The following is a description of a gene set: Human Gene Set: HP_ABNORMAL_NIPPLE_MORPHOLOGY An abnormality of the nipple. species: Homo sapiens Abnormal nipple morphology, and this is the list of marker genes: FGF8 (fibroblast growth factor 8), CHD7, ERCC3, MAP2K1, TRAF7, ALG11, CCDC22, GNPTAB, PIGO, TFAP2A, KDM6B, VPS35L, RRAS2, TNRC6B, UBE2A, ARHGEF2, FIG4, SRD5A3, COX7B, KIAA0586, GPC3 (NCBI Gene Id 6394), KDM5B, PEX3, KRAS, FGFR2, SOS1, TOGARAM1, DHCR7, HDAC4, ALG2 (NCBI Gene Id 85365), CDK13, IDH1, MADD, HNRNPK, AHDC1, SMS, PIK3CD, SOX6, WASHC5, ANTXR1, IBA57, CPLX1 (NCBI Gene Id 10815), DPAGT1, DPM1, BICRA, RAB3GAP2, ZMYND11, WDR37, GNB2, SPIN4, RTL1, CARS1, TTC5 (tetratricopeptide repeat domain 5), GNRH1, CHRNG, RIT1, ABCD4, LAMA5, SLC25A46, HS2ST1, FGF17, ARCN1 (archain 1), RAF1, PROK2, COLEC11, TFAP2B, CHST3, KATNB1, LBR, PORCN, HDAC8, UBR1, FREM2, PPP1CB, ACOX1, CTBP1, DUSP6, GNRHR, WASF1, RNF113A, INSR, CBL, WDR19, TARS1, MGAT2, NFIX, DEF6, TIMM50, TAF4, HS6ST1, PIGW (phosphatidylinositol glycan anchor biosynthesis class W), PIGY, PACS1, SPRED2, CCDC47, PSAT1, MPLKIP, GTF2E2, ERMARD, EIF4A2, EFNB1, ALG8, KDM1A, WNT7A, KIF15, PIGT, COLEC10, IKBKG (inhibitor of nuclear factor kappa B kinase regulatory subunit gamma, NCBI Gene Id 8517), PNPLA6, CILK1, RNF216, DPYSL5, SPRY4, TWIST2, EZH2, B3GLCT, H4C9, MAN1B1, PIGG, NELFA, FAT4 (FAT atypical cadherin 4), ALG12, AMMECR1, TUBB, H3-3A, PGAP3, TACR3, CSPP1, NSUN2, B4GALT1, KNSTRN, RAD21, ERCC6, SRY, ACTB, TMEM94, MAPRE2, PIGL, ARHGAP31, KISS1R, BRAF, RFT1, LETM1, WNT3, SMARCA2, RNU4-2, DDX6, GNE, RIPK4, ADNP, NHLH2, COG7, SMPD4, CDH11, TCF20, NSD2, PTPN11, NRAS, KRT10, PPP2R5D, VAC14, STAG1, KDM6A, KISS1, TMCO1, ZNF148, NSMF (NMDA receptor synaptonuclear signaling and neuronal migration factor), FRAS1, C18orf32, TAC3, MRAS, EED, PIGN, CHAMP1, WAC, GDF11, ZEB2, KAT6A, USP9X, BRD4, GTF2H5, SLC4A10, TAF6, NONO, MAB21L1, PTPRF, ALG14, GRIP1, PROKR2, ALG3, SLC35A2, EXTL3, ALG9, TBL1XR1, TRRAP, CPT2, EBF3, AMER1, PIGV, MASP1, SMC3, AARS1, SOS2, DHODH, FGFR1, ZC4H2, CKAP2L, GPC4, RRAS, EXOC2, IGF1R, KMT2D, PMM2, MEGF8, JARID2, SETBP1, GATA4, KANSL1, COG1, SET, INTU, NIPBL, MDH2, DLK1, KMT2B, WLS, PGAP2 (NCBI Gene Id 27315), ATN1, NUP188, PEX2, SLC25A24, RAB18, EDARADD, TP63, TBX4, RASA2, STT3A, RSPO2, UBA2, KCTD1, CERT1, TCF4, NECTIN1, CACNA1C, ASH1L, WDR11, CDH2, ERCC2, ASXL1, LZTR1 (NCBI Gene Id 8216), RERE, MEG3, EDA, SMC1A, KIFBP, TBX3, ASXL3, NF1